The following is a description of a gene set: Pathway Definition from KEGG: YopP/J -| (MEK,MKK3/6,MKK4/7) Human Gene Set: KEGG_MEDICUS_PATHOGEN_YERSINIA_YOPP_J_TO_TLR2_4_MAPK_SIGNALING_PATHWAY species: Homo sapiens Yersinia YopP/J to TLR2/4-MAPK signaling pathway. Pathway ID: N00862. Pathway type: Pathogen. Pathway class: nt06517 TLR signaling., and this is the list of marker genes: MAP2K1, MAP2K7, MAP2K3, MAP2K2, MAP2K4, MAP2K6